Given this list of marker genes SMARCA2, SMARCD2, ACTL6B, ASXL1, SMARCD3, SMARCB1, ARID1B, KMT2C, RBBP5, KDM6A, SMARCA4, DPY30, NCOA6, ASH2L, SMARCD1, MBD5, PAGR1, WDR5, PAXIP1, RXRA, NR1I3, BAP1, SMARCC2, H3-3A, SMARCC1, ACTL6A, ARID1A, EHMT1, H3-3B, here is a description of the gene set: studied in species Homo sapiens Human Gene Set: WP_KLEEFSTRA_SYNDROME Kleefstra syndrome